The following is a description of a gene set: studied in species Homo sapiens Enables the transfer of glutathione, the tripeptide glutamylcysteinylglycine, from one side of a membrane to the other. Human Gene Set: GOMF_GLUTATHIONE_TRANSMEMBRANE_TRANSPORTER_ACTIVITY, and this is the list of marker genes: ABCC5, SLC25A39, ABCC4, SLC13A3, GJA1 (NCBI Gene Id 7953), SLC25A40, ABCC1